Given this list of marker genes TRAF7, GNRH1, HJV, HS6ST1, SMARCE1, FGF17, NSMF, SLC40A1, BAP1, AIP, PIGA, MEN1, KISS1, DUSP6, PIK3CA, PROKR2, GNRHR, HAMP (hepcidin antimicrobial peptide), GUCY1A1, TAC3, HEXB, PDGFB, SACS, ENSG00000288330, ABCD1, SMO, SMARCB1, CHD7, CDKN2C, LMNB1, FMR1, SPRY4, TERT, WDR11, KISS1R, FGF8, CDKN1A, CACNA1G, PROK2, TFR2, BMP2, TACR3, NHLH2, ATXN8OS, HFE, SUFU (SUFU negative regulator of hedgehog signaling), CDH23, CDKN2B, TTR, COQ2, NF2, AKT1, FGFR1, CDKN1B, GPR101, here is a description of the gene set: Impotence Inability to develop or maintain an erection of the penis. studied in species Homo sapiens Human Gene Set: HP_IMPOTENCE